Given this list of marker genes PCSK1N, DPCD, TRIT1, POLL, KLHDC8B, ALS2, CADM1, NCDN, ZNF287, TCTN2, GDF1, AGTR2, CAMK2A (NCBI Gene Id 815), GAST, TBC1D16, LINC01138, PANK2, LMNTD2, MPC2, ZNF532, RAB36, QRFP, AARSD1, OSBPL2, DUSP14, GPR17, AGAP2, GAPDH, ORAI3, TSGA10IP, HDAC4, CFAP52, HCN4, JAKMIP2, CLIP1, CASKIN1 (NCBI Gene Id 57524), SAMTOR, FGD4, SHANK1, LDB1, INO80B, NIM1K, DNAJC24, SEMA4B, ZNF24, GPR162, CHL1, CERS1, CALY, APOBEC4, ABHD8, ATOSB, XPR1 (NCBI Gene Id 9213), SRGAP2, NRSN2, ZP1, LINC01973, KIF3A, PRKCG, MPP2, C17orf58, DTNA, PRRT1, YWHAZ, PHC1 (polyhomeotic homolog 1), RFX4, SYT6, SPATA6, ATP1A3, SPAG8, DCSTAMP, TNKS1BP1, HSD17B8, VRK3 (VRK serine/threonine kinase 3), HPCAL4, ELMO1, SPATA2, YWHAE, NUDT2, WDR47, DHX30, AP3M2, TP53BP1, MPPED2, PNMA8A, IQCE, ARMC2, NDUFA8, DUSP3, LRRC49, CFAP36, TMEM31, LMO3, ATP2B4, DNAAF11, PARP8, NLGN3, HSPB9, USF1, DAAM1, NR4A3, SOX3, FXYD6, FKRP, BASP1-AS1, DNAAF2, PBXIP1, PITPNM1, BATF, FNDC9, C10orf67, MZF1, CHST8, RAI2, PPM1E, NKX2-8, DCDC1, PHTF1, PPP1R17, LRRC23, DNAAF3, PCF11, MROH9, FYN, PIM2, DOC2A, THAP10, HSPH1, STRN4, CFAP53, TSHZ2, LAMP5, KATNAL1, SPATA2L, RNF139, AP1S1, MORN5, KCNK15, CHCHD3, E2F1 (E2F transcription factor 1), CFAP91, PDZRN4, PPT2, HOXD12, RUNDC1, KIF9, MINK1, STX8, ANK2, SMARCAD1, SLC37A1, FOXH1, RRAD, YWHAQ, DENND2B, ANKRD45, CDK2AP2, STOML2 (stomatin like 2), TSPYL4, TUBB4A, CAMKV, NUMB, HHEX, KCNIP2, NOS1, FXYD1, FAIM2, PSD, KLHL18, MAPK10, RPL35A, CELF6, TAF6L, GDF10, GRIN2D, CIPC, here is a description of the gene set: Comprehensive identification of all functional elements encoded in the human genome is a fundamental need in biomedical research. Here, we present a comparative analysis of the human, mouse, rat and dog genomes to create a systematic catalogue of common regulatory motifs in promoters and 3' untranslated regions (3' UTRs). The promoter analysis yields 174 candidate motifs, including most previously known transcription-factor binding sites and 105 new motifs. The 3'-UTR analysis yields 106 motifs likely to be involved in post-transcriptional regulation. Nearly one-half are associated with microRNAs (miRNAs), leading to the discovery of many new miRNA genes and their likely target genes. Our results suggest that previous estimates of the number of human miRNA genes were low, and that miRNAs regulate at least 20% of human genes. The overall results provide a systematic view of gene regulation in the human, which will be refined as additional mammalian genomes become available. Human Gene Set: GTTRYCATRR_UNKNOWN species: Homo sapiens Genes having at least one occurrence of the highly conserved motif M37 GTTRYCATRR in the regions spanning 4 kb centered on their transcription starting sites. The motif does not match any known transcription factor binding site. from publication Xie X, Lu J, Kulbokas EJ, Golub TR, Mootha V, Lindblad-Toh K, Lander ES, Kellis M (PMID 15735639)